Given this list of marker genes ARVCF, SEC24C, GP1BB, POLR3A, POLG2, CACNA1S, AIRE, SLC12A3, TSHR, THRB, TBX1, CLCNKB, KCNJ2, DICER1, POLG, BTNL2, SUGCT, RREB1, UFD1, TBCK, KCNJ18, FOXP3, CDH23, SLC25A4, KEAP1, HLA-DRB1 (NCBI Gene Id 730415), PIK3CA, GABRA3 (NCBI Gene Id 2556), JMJD1C, HIRA, AKT1, MSTO1, FMR1, COMT, PTEN, GNAS, RRM2B, TWNK, here is a description of the gene set: An abnormality of thyroid physiology characterized by excessive secretion of the thyroid hormones thyroxine (i.e., T4) and/or 3,3',5-triiodo-L-thyronine zwitterion (i.e., triiodothyronine or T3). Human Gene Set: HP_HYPERTHYROIDISM species: Homo sapiens Hyperthyroidism